The following is a description of a gene set: Reactome Pathway: UCH proteinases DUBs of the Ub C-terminal Hydrolase (UCH) family are thiol proteases that have an N-terminal catalytic domain sometimes followed by C-terminal extensions that mediate protein-protein interactions. Humans have four UCH DUBs (UCH-L1, UCH-L3, UCH37/UCH-L5, and BAP1) that can be divided into the smaller UCH DUBs (UCH-L1 and UCH-L3), which cleave small leaving groups from the C-terminus of ubiquitin, and the larger UCH DUBs (UCH37 and BAP1), which can disassemble poly-Ub chains. species: Homo sapiens part of: Deubiquitination, and this is the list of marker genes: PSMD8, SMAD7, H2AC4, UBB, H2AC20, UBA52, PSMB5, UBC, FOXK2, PSMC5, PSMA6, KDM1B, PSMC3, ASXL1, ACTB, ADRM1, PSMB4, PSMB1, INO80B, NFRKB, RPS27A, INO80E, PSMD3, INO80C, USP15, H2AC25, H2AC14, YY1, PSMB2, TGFBR1, RUVBL1, PSMD13, TGFB1, UCHL3, PSMA1, INO80, SEM1, H2AC21, PSMA5, H2AC1, ASXL2, PSMD2, OGT, H2AC18, ACTR5, H2AC7, TGFBR2, INO80D, TFPT, PSMD7, PSMA7, SENP8, FOXK1, PSMD6, ACTL6A, PSMD14, NEDD8, PSMC4, MCRS1, BAP1 (BRCA1 associated deubiquitinase 1), PSMD11, H2AC12, PSMC6, PSMB6, MBD6, H2AC6, PSMA3, UCHL5, PSMB7, MBD5 (NCBI Gene Id 55777), BARD1, PSMA2, H2AC11, ACTR8, PSMC2, PSMC1, UCHL1, HCFC1 (NCBI Gene Id 8267), PSMB3, PSMD1, PSMA4, PSMD12